Given this list of marker genes RABGGTB, PGGT1B, MUSK, CHM, CHML, RABGGTA, FNTA, here is a description of the gene set: Human Gene Set: GOBP_PROTEIN_GERANYLGERANYLATION The covalent attachment of a geranylgeranyl group to a protein. studied in species Homo sapiens